Given this list of marker genes GALNS, GART, SH3GL1, DCLK1, PPP2R5B, CLPTM1, AFDN, PDSS1, MEX3C, RAB40C, here is a description of the gene set: Genes predicted to be targets of miRBase v22 microRNA hsa-miR-6729-5p in miRDB v6.0 with MirTarget v4 prediction scores > 80 (high confidence targets). from publication Chen Y, Wang X (PMID 31504780) Human Gene Set: MIR6729_5P studied in species Homo sapiens